Given this list of marker genes Haspin, Tle4 (NCBI Gene Id 70490), Sp4, Ythdc2, Fyttd1 (forty-two-three domain containing 1), Lmnb1, Gpm6a, Cap1, Adgre5, Pramel22, Siah1b, Pmp22, Chmp3, Gabrg1, Nr6a1, 2810459M11Rik, Abl2 (ABL proto-oncogene 2, non-receptor tyrosine kinase), Nbdy, Rfx4, Pafah1b1, Pbx3, Naa20, Parp14, Pramel27, Hmgb1, Zfp292, Mrgprb2, Mier1, Mzt1, Glyr1, Ctdspl2, Atp6ap2, Fbxl17, Tmem135, Usp32, Ldoc1, Csnk1a1, Erbb4, Vps37a, Mycn, Slc4a10, Cacnb4, Cpeb2, Bend4, Pdcd10, Ccng2, Fst, Snrk, Prkag2 (protein kinase, AMP-activated, gamma 2 non-catalytic subunit), Cadm1, Dhx15, Crxos, Srsf11, Baz2a, Son, Tmem200a, Mrps33, Hnrnpm, Ublcp1, Slitrk4, Ermn, Dhfr, Sox6 (SRY (sex determining region Y)-box 6), Agtr1b (NCBI Gene Id 11608), Ptpdc1 (protein tyrosine phosphatase domain containing 1), Sec61a2, Zfp36l1, Foxp1, Txndc16, Ier3ip1, Cep170, Fmr1 (fragile X messenger ribonucleoprotein 1), Qrfprl, Tm9sf2, Zyg11b, Nipal1, Gm4884, Mtus1, here is a description of the gene set: Genes predicted to be targets of miRBase v22 microRNA mmu_miR_505_3p in miRDB v6.0 with MirTarget v4 prediction scores > 80 (high confidence targets). Mouse Gene Set: MIR_505_3P from publication Chen Y, Wang X (PMID 31504780) species: Mus musculus